The following is a description of a gene set: Human Gene Set: GSE19941_LPS_VS_LPS_AND_IL10_STIM_IL10_KO_MACROPHAGE_UP Bone marrow-derived macrophages were produced from mice lacking IL-10 alone (IL10-def) or mice lacking both IL-10 and the p50/p105 subunit of NF-kB (p50/IL10), and left unstimulated, stimulated with LPS (1 ng/ml) or stimulated with LPS and IL-10 (0.3 ng/ml). Genes up-regulated in IL10 knockout macrophages stimulated by LPS versus those also stimulated by IL10. species: Homo sapiens from publication Yang HT, Wang Y, Zhao X, Demissie E, Papoutsopoulou S, Mambole A, O'Garra A, Tomczak MF, Erdman SE, Fox JG, Ley SC, Horwitz BH (PMID 21217011), and this is the list of marker genes: ANAPC7 (NCBI Gene Id 51434), DGKH, PCBP1, GYS1 (NCBI Gene Id 2997), GAS2L3, ANXA2, H2AC25, CCDC124, EIF6, NPRL2, CENPA, STX2, SSRP1, FIGNL1, DHX35, ARRDC1, ATP1A1, TSPAN32, DERA, QPCTL, PSMD14 (NCBI Gene Id 10213), BAZ2B, EIF3D, PYCARD, CDCA8, GLCCI1 (NCBI Gene Id 113263), ERCC6L, ZBTB8A, CERK, HADH, WDPCP, ITGB7, SPAG5, BSDC1, SNX15 (sorting nexin 15), PLK1, MDM1, PARM1, POLD1, DOT1L, POLE2, CDCA7, H2AX, KIF11, SFN, INCENP, DEPDC1, TPX2, ZW10, PAN2, BUB1B, CDC25B, CDK2, CD99L2, PPP5C, BLVRA (biliverdin reductase A), CD160, PREX1, ZC3HC1, IQGAP3, RAPH1, MTFR2, DEPDC1B, H1-1, MKI67, LRRC8A, ESPL1, MPRIP, ABRAXAS1, TMEM39B, CKAP2L, COG6, NCAPD2, TROAP (trophinin associated protein), TBC1D22A, GTSE1, FADS2, NELFCD, RDM1, RIDA, SOX4, ANAPC2, CTNND1, COLGALT1, GPN2, MIS18BP1, RAD51B, CDK1, KIF2C, ACY1, TFPI, SEPTIN8, POFUT2, ELOF1, ASF1B, EIF3L (eukaryotic translation initiation factor 3 subunit L), RPN2 (NCBI Gene Id 6185), PLIN2, SSR2, SLAMF1, TCF4, PWP1, CHTF18, KCNAB2, PHACTR4, POLR2I, IGF2BP3, ATP2A3 (NCBI Gene Id 489), CDCA5, KNL1, CLIC4 (NCBI Gene Id 25932), DHRSX, PTGR1, ANP32A, TK1, VPS72, WDR76, CKAP5, PPP1R10, E2F1, BEX3, LSM4, IKZF2, PSMD13, CAT, SMARCAL1, E2F8, XYLT1, DHDDS, HDAC1, PDE4D, RNF187, SYCE2, TAF12, POLA2, DNAJC6, BAK1, NCBP2, KIF23, POLH, FBXO5, SF3B2, GTF2H4, CDC20, PIH1D1, ARHGAP19, UBE2S, IL12RB2 (NCBI Gene Id 3595), KIF18B, USP5, MCM2, CREB1, ATP5IF1, EIF3I, EDARADD, FBXO42, TTK, H2AC4, PRKAR2B, NEMP1, FKBP4, SGO1, ITM2A, LAMC1, SUN1, PIMREG, MYO1E, NMRAL1, MOSPD3, AURKA, CEP85, DPP3, MED24, SUSD2, AHDC1, BMAL1, PPM1G, SWAP70, MAP2K6, ANLN, SMPDL3B (NCBI Gene Id 27293), CIT